The following is a description of a gene set: studied in species Homo sapiens Reactome Pathway: Signaling by NOTCH The Notch Signaling Pathway (NSP) is a highly conserved pathway for cell-cell communication. NSP is involved in the regulation of cellular differentiation, proliferation, and specification. For example, it is utilised by continually renewing adult tissues such as blood, skin, and gut epithelium not only to maintain stem cells in a proliferative, pluripotent, and undifferentiated state but also to direct the cellular progeny to adopt different developmental cell fates. Analogously, it is used during embryonic development to create fine-grained patterns of differentiated cells, notably during neurogenesis where the NSP controls patches such as that of the vertebrate inner ear where individual hair cells are surrounded by supporting cells.<br>This process is known as lateral inhibition: a molecular mechanism whereby individual cells within a field are stochastically selected to adopt particular cell fates and the NSP inhibits their direct neighbours from doing the same. The NSP has been adopted by several other biological systems for binary cell fate choice. In addition, the NSP is also used during vertebrate segmentation to divide the growing embryo into regular blocks called somites which eventually form the vertebrae. The core of this process relies on regular pulses of Notch signaling generated from a molecular oscillator in the presomatic mesoderm.<br>The Notch receptor is synthesized in the rough endoplasmic reticulum as a single polypeptide precursor. Newly synthesized Notch receptor is proteolytically cleaved in the trans-golgi network, creating a heterodimeric mature receptor comprising of non-covalently associated extracellular and transmembrane subunits. This assembly travels to the cell surface ready to interact with specific ligands. Following ligand activation and further proteolytic cleavage, an intracellular domain is released and translocates to the nucleus where it regulates gene expression. part of: Signal Transduction, and this is the list of marker genes: PSMB2, STAT1, KAT2B, TMED2 (transmembrane p24 trafficking protein 2, NCBI Gene Id 10959), AGO4, PSMD12, MIR34B, H2AC4, WWC1, YWHAZ, DLGAP5, H2BC1, WWP2, TFDP2, PSMD13, PSMD1, MDK, EGFR, PSMD2, PSMC2, PSMD8, E2F1, H2BC9, EGF, TNRC6B, NOTCH2, NCSTN, SNW1 (SNW domain containing 1), H2AC7, PSMA4, H3-3A, MAML3, ELANE, TP53, MIR181C, H2BC12L, TLE2, ST3GAL3, RUNX1, HES5 (hes family bHLH transcription factor 5), MIR34C, HDAC1, UBB, H2BC11, H2AZ2, DLK1, H2BC14, PSMA3, NOTCH2NLR, H2BC17, MAML1, E2F3, PSMB6, PSMA7, PSMA1, TNRC6A, HEY2, RPS27A, JUN, NOTCH2NLC (notch 2 N-terminal like C), NCOR2, HDAC6, H2AX, MIR449A, PSMB1, HDAC3, TFDP1, AGO3 (NCBI Gene Id 79910), ATP2A2, TBL1X, ST3GAL6, JAG1 (jagged canonical Notch ligand 1), SEM1, HDAC2, HDAC9 (histone deacetylase 9), H2BC21, ATP2A1, DLL1, H2BC15, MAML2, H2AC18, RAB6A, APH1A, IKZF1, CREB1, MAMLD1, RBX1, PBX1, AGO1, FLT4, DLL4, ACTA2, TLE1, POGLUT1, PSMA2, CREBBP, PSEN1, TNRC6C, ADRM1, HDAC5, MIR200C, ITCH (NCBI Gene Id 83737), NOTCH2NLA, PTCRA, NUMB, SKP1, CCNC, H2BC5, HDAC10, H2AC20, GZMB, PSMB3, PSMD7, FBXW7, MIR449B, ELF3, YBX1, DNER, PSEN2, TACC3 (transforming acidic coiled-coil containing protein 3), H3C1, RFNG (RFNG O-fucosylpeptide 3-beta-N-acetylglucosaminyltransferase), JAG2, MIR150, NCOR1, CCND1, MIR34A, PSMB5, PSMD11, NOTCH3 (notch receptor 3), NOTCH1, PSENEN, FABP7 (NCBI Gene Id 2173), H2BC3, NEURL1, CDK8, H4C1, TLE4, HDAC7 (histone deacetylase 7), H2AC6, EP300, H2AC14, MIR449C (NCBI Gene Id 100313923), H2BC26, MYC, UBA52, H3C15, MIB2, ARRB1, DTX4, PSMB4, MIB1, HDAC8 (histone deacetylase 8), POFUT1, PSMB7, PSMC5, H2BC13, NOTCH4, MFNG, KAT2A, HIF1A, PSMA5, ATP2A3, FURIN (NCBI Gene Id 5123), TLE3, NEURL1B, PRKCI, CUL1, MIR200B, HES1, ARRB2, H2AB1, PLXND1, ST3GAL4, H2BC12, HDAC4, MOV10, HEYL, PSMC6, ADAM10 (NCBI Gene Id 102), PSMD6, PSMC3, NOTCH2NLB, LFNG, RBPJ, H2BC4, PSMC4, MIR302A, SMAD3, PSMA6, SIRT6, SEL1L, MIR206, CNTN1, B4GALT1, H2AJ, DTX1, UBC, AKT1, FCER2, AGO2, TBL1XR1, DTX2, APH1B, PSMD14, ADAM17, PSMD3, PSMC1, HDAC11, HEY1, NBEA